Given this list of marker genes S100a10, Jun, Ltb, Fos, Klf2, Crip1, Hspa1a, Hspa1b, Klf6, here is a description of the gene set: Mouse Gene Set: CUI_T_CELL_CD8_OSM_RESPONSE_DN species: Mus musculus from publication Cui A, Huang T, Li S, Ma A, Pérez JL, Sander C, Keskin DB, Wu CJ, Fraenkel E, Hacohen N (PMID 38057668) Cytokines mediate cell-cell communication in the immune system and represent important therapeutic targets. A myriad of studies have highlighted their central role in immune function, yet we lack a global view of the cellular responses of each immune cell type to each cytokine. To address this gap, the authors created the Immune Dictionary, a compendium of single-cell transcriptomic profiles of more than 17 immune cell types in response to each of 86 cytokines (>1,400 cytokine-cell type combinations) in mouse lymph nodes in vivo. A cytokine-centric view of the dictionary revealed that most cytokines induce highly cell-type-specific responses. For example, the inflammatory cytokine interleukin-1β induces distinct gene programmes in almost every cell type. A cell-type-centric view of the dictionary identified more than 66 cytokine-driven cellular polarization states across immune cell types, including previously uncharacterized states such as an interleukin-18-induced polyfunctional natural killer cell state. Genes negatively differentially expressed in cell type: CD8+ T cell upon treatment with cytokine: OSM in mouse lymph nodes in vivo.